Given this list of marker genes TFE3, BTBD9, PCIF1, C3orf70, ERG, PDE1A, RAP1GAP2, SNX18, MICAL3, OTOR, GDNF, DAAM2, JDP2, ZNF559-ZNF177, PHF20L1, AOC3, C14orf93, MKLN1, NAA50, NAV1, NXPH3, PEG3, IL25, NFIC, POFUT2, C10orf105, ERCC3, C16orf90, MBNL2, TPM3, ZNF177, EFNB3, TNRC6B, GRAMD1B, MAPKAPK2, LAMP5 (lysosomal associated membrane protein family member 5), NUDCD1 (NCBI Gene Id 84955), TMEM223, CACNG8, RASSF1, NYAP1, GLB1L2, SOD2, CD274, PEG10, BCL2L13, AFF1, PSD3, FOSB, HOMER1, CDCA2, ST3GAL6, ATP6AP1L, RGS3, GLIS3, EHD3, EID1, GPD1, RHOBTB2, GJB1, CCR5, PEA15, TASOR, SLC38A5, PRKAG1, LINC03103, GPR68, SRP19, PLEKHO2, MIEF2, GLP1R (glucagon like peptide 1 receptor), NFAM1, RXFP3, CHRM1, SPANXN1, ZNF24, SGO2, PCDH15, TECPR2, PLCXD2, PTPN3, CAMK2N1, GPR107 (NCBI Gene Id 85011), PNMA5, ABCC12, NDOR1, MATCAP1, WNT9B, PRMT3, ZNF250, C1orf52, ATAD1, NLN, UST, NACC2, KDM5C, CCNF, PLCG1, DLL4, SCG5, KCNQ2, MB, AMACR, SFMBT2, CBR1, PID1, BUB3, RAB3GAP2, SP6, CACNA1C, ATP2B4, PIGR, HRH1, NFATC4, YAF2, PRG2, MTFR1L, EPHA8, FAM167B, SLC22A6, ACACA, NLGN1 (NCBI Gene Id 22871), DTNA, RPS9, DLG3 (NCBI Gene Id 89363), PIAS3 (protein inhibitor of activated STAT 3), LRCH1, FADS1, THSD1, AKIRIN1, KCNQ5, ALX4, NEDD4L (NEDD4 like E3 ubiquitin protein ligase), SOX6, EAPP, ARPC2, PALM2AKAP2, ZNF827, NAA11, ATF6, LIM2, KCNH5, UBN2 (ubinuclein 2), ADD1, AP3S1, RELT, UNC5C, DCAF7, ELOVL6, STIM1, GRM7, UBA3, DST, SLC6A6, SPANXN5, POLR2F, RFPL4B, CCNY, MRPS35, EPB41L1, CCDC9B, S1PR3, AMOTL1, MGAT5, AMZ1, GRM1, GFAP, SSR1, IREB2, TBC1D2B (TBC1 domain family member 2B), IFNLR1, ATP8B2, SCN8A, here is a description of the gene set: Human Gene Set: MIR5193 Genes predicted to be targets of miRBase v22 microRNA hsa-miR-5193 in miRDB v6.0 with MirTarget v4 prediction scores > 80 (high confidence targets). from publication Chen Y, Wang X (PMID 31504780) species: Homo sapiens